The following is a description of a gene set: species: Mus musculus The chemical reactions and pathways resulting in the formation of a nucleoside diphosphate, a compound consisting of a nucleobase linked to a deoxyribose or ribose sugar esterified with diphosphate on the sugar. Mouse Gene Set: GOBP_NUCLEOSIDE_DIPHOSPHATE_BIOSYNTHETIC_PROCESS, and this is the list of marker genes: Cad, Umps (NCBI Gene Id 73572), Ak4, Entpd8, Dtymk, Ak3, Ak9, Dhodh, Guk1, Ak1, Ak2, Cmpk1, Cmpk2